Given this list of marker genes VEGFA, GATA2, GATA1, HSCB, STK3, THOC5, ZFPM1, TAL1, STK4, here is a description of the gene set: studied in species Homo sapiens A first transient wave of blood cell production that, in vertebrates, gives rise to erythrocytes (red blood cells) and myeloid cells. Human Gene Set: GOBP_PRIMITIVE_HEMOPOIESIS